The following is a description of a gene set: Genes predicted to be targets of miRBase v22 microRNA hsa-miR-6776-5p in miRDB v6.0 with MirTarget v4 prediction scores > 80 (high confidence targets). from publication Chen Y, Wang X (PMID 31504780) Human Gene Set: MIR6776_5P species: Homo sapiens, and this is the list of marker genes: MCMDC2, SLC24A2, CD74, SIM1, NKTR, EFNB3, PMM2, ATF2, EGFL8, NKX3-1, CLDN16, SKI, GAREM2, SELENOT, SPRING1, CRP, DNMT3A, NCKAP5L, PAX5, F10 (coagulation factor X), PDE6A, PNMA8B, GIPC3, CASP10 (caspase 10), RNF170, UBFD1, POU3F3, F2RL2 (coagulation factor II thrombin receptor like 2), PHF5A, C18orf63, ZC3H6, CHRM3, KLF8, AFMID, BPY2C, EXOC6B, CACNA1E, GPI, PEG10, HSD3B7, ZNF181, DNAAF9, RGL4, DPYSL5, IKZF3, CDHR3, CERS2, PHB1, ZFR2, MVB12B, CREB3L3, LZTS2, MYO6, ZBTB40, PPCDC, EAPP, HDAC6, TMEM127, SYNGAP1, HDGF, TMED7-TICAM2, ACACB, LRRC25, ENTREP2, NBEA, MAST3, CLIP3, EOGT, CNOT6, DTNBP1, OLFML2A, MARCHF10, INHBB (inhibin subunit beta B), ABLIM1, SMG6, SFTPB, SYNGR2, TRIM67, ZNF607, CEP250 (centrosomal protein 250), ZNF302, IFI6, FBXO41, TPPP3, TICAM2, TRPV6, ANKRD6, BPY2, B3GALNT2, PDE3A, BPY2B, ZFR, ZNF823, ZNF292, COL23A1, AZIN1, TJP1